The following is a description of a gene set: Genes predicted to be targets of miRBase v22 microRNA mmu_miR_3103_5p in miRDB v6.0 with MirTarget v4 prediction scores > 80 (high confidence targets). from publication Chen Y, Wang X (PMID 31504780) studied in species Mus musculus Mouse Gene Set: MIR_3103_5P, and this is the list of marker genes: Shmt2, Mucl2, Samhd1, Tmem9 (NCBI Gene Id 98706), Tmem104, Naa60, Ap1s3, Prelp, Lpar2, Atp1b2, Matcap1, Lrrc7, Atp1a3, Wnt4, Synj2bp, Bard1, Psmg2, Frs2, Flrt2, Tppp, Srp54c, Mecp2, Rpp40, Lax1, Shisa6, Chst1, Limd2, Zfp64, B3gat2, Prdm2, Ifi203, Klhl20, Nr2c1, Npnt, Thsd7a, Septin3, Gnat1, Cux2, Zc3hav1l, Mip, Rnf152, Nfat5, St3gal1, Banf1, Slc9a8, Jazf1, Plxna4, Sytl4, Mycl, Syp, Aoc3, Eif4e1b, Dhx40, Hnrnpll, Galnt17, Slc4a8 (NCBI Gene Id 59033), Naga, Otof (NCBI Gene Id 83762), Focad, Bsn, Haus5, Grip1 (glutamate receptor interacting protein 1), Pak3, Ankrd63, Htt, Rsl24d1, Dusp23, Pakap, Chd3, Hdgf, Rho, Mapre1, Nbl1, Zfp395, Tbcel, Dusp16, Dcaf17, Eif4b, Klk4, Kpna6, Nkain2, Erv3, Dtx4, Sh3gl2, Rgs20, Ldlrad3 (low density lipoprotein receptor class A domain containing 3), Lurap1, Ccdc32, Msi2, Igf2bp2, Wdtc1, Fgf10, Arf3, 6430548M08Rik, Got2, Il17re, Vti1a, Mdga2, Fmo5, Cyyr1, Prickle2, Trim58, Kansl1, Wiz (NCBI Gene Id 22404), Slc7a1, Fam171a1, Rprd2, AI837181, Pianp, Gadd45gip1 (NCBI Gene Id 67697), Frmd5, Eya3, Rbm20, Lhx2, Sash1, Setd7, Crp, Ndufa2, Atxn1, Taok3, Epb41l4a, Rpgr, Rab5b, Nectin1, Nnat, Mul1, Kcnj10, Ptprn, Fbxw8, Aqp6, Serpine1, Tbc1d22b, Iffo2, Ppbp, Slc25a23, Zfpl1, Scrn3, Astn2, Nup205, Nedd4l, Srp54b, Fgfr1, Dnal1, Zfp26, Itsn1, Tfdp2, Zbtb34, Gabrg2, D2hgdh, Gas7, Dnajb2